Given this list of marker genes Derl2, Mrps28, Psmd4, Ssr4, Rpn1, Slco3a1, Hsbp1, Grhpr, Selplg, Tubb2b, Ccnd2 (cyclin D2), Anp32b, Sell, Cct8, Fgr, Pfkp, Ywhah, H2aj, Slc25a5, Cfl1, Cope, Txn1, Aars1, Uqcrb, Tap2, Hnrnpa3, Ddx39a, M6pr, Dad1, Mrps14 (mitochondrial ribosomal protein S14), Pdia4, Arhgdia, Atp6v0e, Cyp7b1, Psme2, Ran, Psma3, Parp14, Psmb4, Cct3, Prdx5, Reep5 (NCBI Gene Id 98127), Atp6v1g1, Tma7, Rala, Ostc, Hspa8, Atp5f1b (NCBI Gene Id 11947), Vasp, Ly86, H2-T22, Nip7, Idi1, Psmb8, Ikzf2, Emc8, Tagln2, Srsf7, Lta4h, Gmfb, Edf1, Cox5b, Mvp, Rexo2, Cnn2, Mrpl21, Psmd14, Rac2, Ly6a, Itm2c, Atp5mc3, Mif, Nsun2, Cacybp, Snx2, Set (SET nuclear oncogene), Tubb4b, Mrpl17, Psmb3, Adh5, Higd1a, Tmed10, Dbi, Ssr1, Pim1, Gng5, C1qbp, Rbm8a, Sdc3, Arid5a, Atp5mf, Myl12a, Gadd45gip1, Cfp, Scd2, Selenos, Erp44, Mrps15, Znrd2, Cltb, Psmb7 (NCBI Gene Id 19177), Cd200r1, Timm10b (translocase of inner mitochondrial membrane 10B), Ndufb6, Eif5a, Sin3b, Ccnd3, Manf, Pik3cd, Mrpl57, Arl1, Cited2 (NCBI Gene Id 17684), Tpm3, Vcp, Sqle, Cdc42, Rbm3, Zfp593, Csf2rb2, Psmd12, Tmed9, Fmnl2 (NCBI Gene Id 71409), Prdx1, Eno1, Jkamp, Snrpd3, Gna15, Sub1, Hnrnpf, Psmb6, Lifr, Arpc1b, Mrpl55, Aldh9a1, Tmem258, Tuba1b, Bet1, Cyb5b, Atxn10, Ftl1, Hnrnpdl, Stt3a, Psmd2, Ppa1, Hsp90b1, Erg28, Psma7, Sfxn1, Nfu1, Sec61g, Dkc1, Cd164, Ift20, Ndufa12, Nrros, Dnajb11, Tuba1a, Ppp1r14b, Wdr18, Eif6, Parp3, Hspa9, Ndufab1, Ldlr, Serp1, Tuba4a, Dock10, Slc3a2, Hspd1, Tubb5, Pfn1, Calm1, Hcls1 (hematopoietic cell specific Lyn substrate 1), Nudt19, Ndufb7, Mrpl12, Rab2a, Hmgn1, Cyp4f16 (cytochrome P450, family 4, subfamily f, polypeptide 16), Cdkal1, Eif1ax, Cnpy3, Atp5pb, Pno1, Pkib, Ube2e1, Cmtm6, Canx, Abracl, Srsf2, Psmb10, Plac8, Actr2, Psmb2, Selenow, Pros1, Agpat5, Anxa6, Ifi44, Gtf3c6, Ppia, Wdr46, Fabp5, Ebna1bp2, Bysl, Chchd1, Pld4, Sdf2l1, Phb1, Fcf1, Ndufa11, Snrpb, Snrpd1, Gnb1, Ybx3, Llph, Tmbim4, Golga7, Edem1, Cops6, Dhcr7, Erh, Ube2l3, Hsd17b12, Orai3, Fdps, Mettl1, H13, Slc29a1, Atp5mc1, Cox7a2 (cytochrome c oxidase subunit 7A2), Chchd2, Nab1, Arpc2, D8Ertd738e, Ncbp1, Gpatch4, Casp3, Cycs, Uck2, Arhgdib, Cstb, Acsl5, Pdcd5, Ssr2, Basp1, Tkt, Mrps24, Chmp2a, Larp1, Il7r, Fh1, Gnb4, Dgkz (NCBI Gene Id 352984), Selenof, Sec61b, Fdft1, Nhp2 (NCBI Gene Id 68237), Slc35b1, Nudt3, Clec10a, Hnrnpa2b1, Myl6, Trafd1, Socs2, Rwdd1, Sc5d, Farsb, Psma2, Rpn2, Snd1, Lman1, Ldha, Get3, Msmo1, Srgn, Ndufb8, Nedd8, Lamtor4, Snf8, Ap2s1, Pcmt1, Gimap1, Krtcap2, Gbp7, Mydgf, Lman2, Ddx21, Tmbim6, Pomp, Cotl1, Slfn2, Ndufb3, Bbip1, Hint1, Mrpl54, Ptpn1, Trim30a, Psmd11, Cnp, Yif1a, Rpia, Coro2a, Lcp1, Eif4a1, Tubb2a, Serbp1, Thyn1, Atp6v1b2, Itsn1, Napsa, Eif4g1, Grpel1, Ass1, Cks1b, Runx1, Ywhab, Gps1, Ppp3ca (protein phosphatase 3, catalytic subunit, alpha isoform), Pdia6, Cct7, Psma4, Gng12, Ly6d, Sec11a, Anp32e, Ndufs6, Calm4, Elovl6, Paqr5, Gsr, B3galnt2, Eif1 (eukaryotic translation initiation factor 1), Capzb, Rftn1, Gapdh, St13, Necap2, Ube2m, Polr2e, Prdx4, Fads2, Taf10, Magoh, Crip1, Rap1a, Uqcc2, Hnrnpab, Bccip, Tmem208, Nop56, Fkbp2, Eef1e1, Lrrc59, Ube2k, Mdh2, Lsm12, Mlx, Mtap, Ndufv2, Mkrn1, Wdr83os, Cyp51, Apex1, Them6, Itgax, Lgals3, Pbdc1, Cox7b, Cd44, Tmed2, Hmgcs1, Tfrc, Spcs2, Nars1, Anks3, Nme1, Srsf1, Gbp3, Sf3b6, Fcer1g, Arl8b (ADP-ribosylation factor-like 8B), H2-DMa (NCBI Gene Id 14998), Atp2b4, Slc35a4, Lypla2, Calr, Bax, Tmem128, Lgals1, Srm, Litaf, Zfp91, Rab5c, Hspe1, Gsn, Nfkb1, Alcam, Psmb5, Bud31, Acot9, Fbl, Ranbp1, Gabarap, Pilra, Ncl, Smdt1, Hmgcr, Plaur, Hsp90ab1, Ctsz, Rrp1, Ybx1, Spcs1, Lsm6, Rbx1, Cox5a, Noc2l, Capg, Sdhaf2, here is a description of the gene set: from publication Cui A, Huang T, Li S, Ma A, Pérez JL, Sander C, Keskin DB, Wu CJ, Fraenkel E, Hacohen N (PMID 38057668) Mouse Gene Set: CUI_PDC_IL3_RESPONSE_UP Cytokines mediate cell-cell communication in the immune system and represent important therapeutic targets. A myriad of studies have highlighted their central role in immune function, yet we lack a global view of the cellular responses of each immune cell type to each cytokine. To address this gap, the authors created the Immune Dictionary, a compendium of single-cell transcriptomic profiles of more than 17 immune cell types in response to each of 86 cytokines (>1,400 cytokine-cell type combinations) in mouse lymph nodes in vivo. A cytokine-centric view of the dictionary revealed that most cytokines induce highly cell-type-specific responses. For example, the inflammatory cytokine interleukin-1β induces distinct gene programmes in almost every cell type. A cell-type-centric view of the dictionary identified more than 66 cytokine-driven cellular polarization states across immune cell types, including previously uncharacterized states such as an interleukin-18-induced polyfunctional natural killer cell state. studied in species Mus musculus Genes positively differentially expressed in cell type: pDC (plasmacytoid dendritic cell) upon treatment with cytokine: IL-3 in mouse lymph nodes in vivo.